Given this list of marker genes Fgf20, Klb, Fgf8, Fgf6, Fgf4, Fgf1, Frs2, Fgfr4, Grb2, Sos1, Kras, Hras, Fgf23, Fgf2, Ptpn11, Frs3, Fgf17, Fgf15, Fgf9, Fgf16, Fgf18, here is a description of the gene set: Mouse Gene Set: REACTOME_FRS_MEDIATED_FGFR4_SIGNALING FRS-mediated FGFR4 signaling species: Mus musculus